Given this list of marker genes Ppp1r9a, Fiz1, Ric3, Gm4884, Cpsf6, Ebna1bp2, Tbc1d5, Tmpo, Map4k5 (NCBI Gene Id 78253), Sez6l, Cbll1, Wee1, Napg, Pik3cb, Ubap1, Vps35, Magea9, Zfp236, Evi5 (NCBI Gene Id 231572), Vkorc1l1, Phf21a, Blcap, Ldhb, Hhat, Ikzf2, Zfp462, Dhrs11, Zbtb26, Agps, Zic4, Necap1, Cks2, Ifnlr1, Neurod1, Sds, Ei24, Gcnt3, Rdh10, Vdac2, Jak1, Pom121, Adam17, Zfp213, Ubn1, Arid5a, Polk, Mbd6, Tmem33, Clk2, Sting1, Slc7a15, Rassf8, Ptprk, Dpysl2, Sh3gl3, Csnk1d, Stxbp3, Gpr141b, Dnaja2, 4931406C07Rik, Cyp1b1, 9130008F23Rik, Wdr45b, Atad2b, Eya1, Brd8, Erbb4, Efna5, Rgs16, Rap1b, Rbm33, Prkaa2, Rit1, Rnf144a, Klhl9, Tmppe, Zfp956, Spred3, Spin2c, Tbc1d30, Spo11, Tle4, Abt1, Rrs1, Zcchc2, Arfgef1, Fbxl3, Serpina7, Edem1, Mex3c, 2410004B18Rik, Lhfpl2, Ggnbp2, Atxn7l1, Jam2, Grsf1, Ndrg2, Add3, Acly, Ythdf3 (NCBI Gene Id 71600), Txndc8, Aldh5a1, Morc3, Shisa8 (NCBI Gene Id 631752), Acad11, Adgre4, Pogz, Arhgap21, Plat, Mavs, Kalrn, Ttyh3, Cdc42se2, Stk25, Angptl7 (angiopoietin-like 7), Vat1, Med13l, Bnipl, Cdkl2, Pitpnm3, Fbxo10, Fam91a1, Pxk, Myo9a, Pcmtd2 (NCBI Gene Id 98894), Prkcsh, 2610008E11Rik, Itga6, Btg1, Cdc14b, Cert1, Ajap1 (adherens junction associated protein 1), Mia3, Man1a2, Mcm2, Il23a, Pfkfb2, Lin52, Pnma1, Zfp329, Mocs2, Trim30d, Chd1, 1700029F12Rik, Wnk3, Agfg1, Luc7l3, Qki, Snn, Syde1, Smcr8, Kmt2a, Elk3, Kcnh1, Prmt2, Evl, Gga3, Npas3, Serpina3b, Rfxap, Strn, Taf8, Bmt2, Luzp2, Lypd6, Prom1, Eogt, here is a description of the gene set: from publication Chen Y, Wang X (PMID 31504780) Genes predicted to be targets of miRBase v22 microRNA mmu_miR_6937_3p in miRDB v6.0 with MirTarget v4 prediction scores > 80 (high confidence targets). species: Mus musculus Mouse Gene Set: MIR_6937_3P